Given this list of marker genes Slc6a16, Slc6a20a, Slc24a3, Bpifa5, Kcnk3, Atp1a1, Bpifa1, Slc6a11, Slc5a11, Slc6a21, Scn9a, Slc41a1, Slc22a4, Slc9a2, Nalcn, Nedd4l, Akt1, Trpm4, Slc4a8, Tmem168 (transmembrane protein 168), Fxyd4, Grin1, Slc38a11, Pon3, Atp4b (NCBI Gene Id 11945), Ednrb, Slc38a5, Slc13a3, Il6, Gpd1l, Nkain4, Slc24a1, Cnnm4, Cnga3, Atp1a4, Scnn1b, Cxcl1, Slc6a19, Scn5a, Slc6a3, Slc4a11, Fxyd1, Slc6a13, Slc34a2, Prss30, Umod, Scnn1g, Scn3b, Ednra, Slc38a7, Trpm2, Slc17a4, Kcnj1, Slc17a2, Slc6a6, Slc38a2 (NCBI Gene Id 67760, solute carrier family 38, member 2), Atp1b1, Slc5a10, Slc5a12, Nedd4, Rangrf (NCBI Gene Id 80408), Grp (gastrin releasing peptide), Scn2a, Dmpk, Slc24a4, Kcne3, Slc8a1, Hcn3, Cpox, Slc13a1, Tescl, Slc4a5, Slc20a2, Fxyd5, Cnga1, Agrn, Gnas, Atp2b4, Kcnk9, Slc12a3, Slc5a4a, Scn4b, Nppa, Serpine2, Guca2b, Atp1b4, Slc4a10, Wnk1, Mfsd4b1, Nkain3, Asic2, Pkd2l1, Asic5, Atp12a, Slc6a5, Scn3a, Slc28a3, Trpv3, Slc13a5, Ikbkb, Nkain2, Fgf14, Adrb2, Slc17a1, Scn1b, Slc6a9, P2rx7, Fgf12, Akt2, Ano6, Nkain1, Slc6a20b, Slc5a1, Atp1b2, Slc6a17, Nkx2-5, Grin2a, Cnga4, Slc5a3, Pcsk9, Commd3, Wnk2, Wnk3 (NCBI Gene Id 546388), Mcoln3, Slc5a6, Oxsr1, Slc10a4, Slc17a6, Atp1a3, Pkd2, Cftr, Slc23a1 (solute carrier family 23 (nucleobase transporters), member 1), Fxyd7, Fxyd2, Gm13629, Nos3, Slc22a5, Maged2, Slc10a1, Tesc, Prss8, Slc5a8, Scn1a, Scn11a, Slc5a9, Slc9a1, Slc9a6, Slc6a8, Slc38a1, Chp1, Arf1, Hcn1, Slc20a1, Fxyd3, Catsper4, Slc8a2, Wnk4, Mllt6, Fgf13, Akt3, Neto1, Slc4a4, Slc4a9, Mcoln1, Asic1, Slc24a2, Scn7a (sodium channel, voltage-gated, type VII, alpha), Slc10a6, Slc8a3, Dot1l, Cav3, Commd1, Slc9a4, Scn10a, Slc6a4, Per1, Slc34a3, Atp6v1b1, Scn2b, Slc6a2, Slc34a1, Atp4a, Slc24a5, Slc6a1, Nos1, Tpcn1, Slc6a7, Cnga2, Catsper3, Slc9b2, Sptbn4 (NCBI Gene Id 80297), Slc12a1, Dmd, Gm5134, Ahcyl1, Scnn1a (NCBI Gene Id 20276), Cntn1, Chp2, Slc9a9, Slc38a3, Slc10a7, Ptpn3, Sgk1, Ywhah, Tpcn2, Slc5a4b, Slc9a8, Slc5a7, Slc13a2, Slc6a18, Slc41a3, P2rx4 (purinergic receptor P2X, ligand-gated ion channel 4), Drd2, Slc9b1, Kcnq1, Slc6a12, Slc17a8, Hcn4 (hyperpolarization-activated, cyclic nucleotide-gated K+ 4), Stk39, Edn1, Slc17a7, Slc9c1, Sik1, Mllt3, Kcnk1, Nherf1, Scn8a, Slc5a5, Cnksr3, Slc8b1, Slc9a5, Atp1a2, Commd9, Slc6a15, Slc9a3, Slc23a2, Slc10a2, Plcb1, Slc38a4, Atp1b3, Scn4a, Slc5a2, Kcnq2, Klhl3, Slc9a7, Trpm5, Asic3, Snta1, Slc4a7, Hcn2, Asic4, Fxyd6, Drd4, Osr1, Slc10a5, Slc12a2, Slmap (NCBI Gene Id 83997), Camk2d, Ank3, Slc6a14, Tgfb1, here is a description of the gene set: The directed movement of sodium ions (Na+) into, out of or within a cell, or between cells, by means of some agent such as a transporter or pore. species: Mus musculus Mouse Gene Set: GOBP_SODIUM_ION_TRANSPORT